Given this list of marker genes RNF168, SUSD5, SPOP, TENM4, AFF4, UBXN7, DNAJC7, TMEM47, CTDSPL2, B3GALNT1, TBX15, ZNF138, PYHIN1, RCN2, NDEL1, TSC22D3, FHL5 (NCBI Gene Id 9457), GPR180, ZNF559-ZNF177, PRKCB, PRDM10, BCLAF3, PIAS2, BMAL2, ZNF721, MSL2, DNAJC21 (NCBI Gene Id 134218), ZFP1, DSE, MSI2, SRSF10, RNF130 (ring finger protein 130), RCOR1, STXBP6, ANKRD28, MAN2C1, HNRNPR, TSPAN6, PFKFB2, ITSN2, SRPK1, SLC4A10, PTPRZ1, ZNF488, PPP2R5A, SH3BP5, TRAPPC10, AK4, CADM1, TSPAN5, ARG1, MIER3, SESN1, DNAJC8, SOCS6 (NCBI Gene Id 9306), RPGR, SAV1, TMPO, WNK1, ARID4A, ZNF302, ADAMTS6, FUNDC1, FUT9, KPNA2, TARBP1, QPCT, IRF2BP2, KRBOX4, RTN4, ACOX1, KIF2A, BAHD1, RAP2B, PGF, ZNF121, FAXC, KCNMB2, ELAPOR2, KIT, AMER2, KDM7A (lysine demethylase 7A), SCN7A, PTBP2, GLS, GAPVD1, FRA10AC1, ZNF257, CAVIN2, OBI1, RANBP1, PIAS1 (NCBI Gene Id 8695), FN1, MYO6, STAG1, MEX3C, EHF, ARMC2, ZNF117 (zinc finger protein 117), RLIM, ZNF75A, ZBTB20, CPNE3, PUM1, IL22RA2, USP42 (ubiquitin specific peptidase 42), FZD3, CALCRL, RICTOR, PCGF2 (NCBI Gene Id 7703), BSN, CHIC1 (NCBI Gene Id 53344), IL15, ZNF586, DUS1L, ARRDC3, GPATCH8, CCL13, SEMA3A, BICRAL, LRRC8C, USP9X (NCBI Gene Id 8239), RAB6B, MBNL2, ZNF844, NECTIN3, ZNF99, NUP58, IKZF3, ZNF266, SLC7A14, GRPEL2, RXRA, FGL2, CAMTA1, VSIG1, FAM53C, DEPTOR, TIGD3, QKI, ATG2B, BAZ2B, POU2F3, CACYBP, ZNF780B, GREM2, ZNF426, TMEM168, B3GNT2, CCL2, PCDHB2, MIA3, TMEM170B, TIAM2, GALNT3, SPICE1, CPSF6, PROCR (protein C receptor), OSTC, THOC2, NID1, TRIM44, CLIC2, ARID2, EYA4, NAA16, ARL17A, M6PR, SGIP1, DDB1, AAK1, ARK2C, ZNF449, FAXDC2, DKK2, CNIH1, SMAP1, ONECUT2, IFIT1B, APIP, ZNF608, ZNF195, ARHGAP12, MIER1, TNRC6A, SAMSN1 (SAM domain, SH3 domain and nuclear localization signals 1), CASK, TRHDE, C2orf49, SECISBP2L, MLLT10, PIM2, ZNF268, GUCY1A2, SRP54, NEXMIF, ZNF704, ANO3, ZNF773, PKP4, SHANK2, AGPS (alkylglycerone phosphate synthase), ZNF544, ADH5, SIX3, G3BP1, SNRK, ASF1A (anti-silencing function 1A histone chaperone), PTPRC, NXPH2, SLC33A1, CDCP1, SLC16A1, YTHDF1, PAWR, ZNF154, MET, CRK, ZFYVE26, TAF5L, FBXO42, INTS6, CDYL2, KBTBD11, GYPA, RHOU, RASEF, ZDHHC17, CREB1, ZNF569, HMGN4, SUB1, TRIM55, XRN2, PABPC4L, ZNF37A, CADM2, SRSF6, ZNF189, ZNF155, ENOX1, SLC30A9, NEK7, PALS1, CA13, ADD3, MAGT1, LCOR, TNPO1, ZNF552 (zinc finger protein 552), TLCD4, GRIK2, SPAG9, ZBTB14, MACO1, AZIN1, MAGEB18, ZDHHC21, FBXO48, NR3C1, SEC62, FUT10, CCDC34, FBXL2, TRIM37, TESMIN, IFTAP, POU2F1, KDM5B, ZNF800, B9D1, PRPF38B, MTRES1, CCDC57, GNAQ, EXOC6, CKAP2L, SPIN1, RALGPS2, ZNF503, ASB1, NSD2, MED26, ZNF678, ERMN (NCBI Gene Id 57471), CERT1, HEPACAM2, OGT, SNAP25, SPO11, ZNF718, KCNJ15, CDK6, RBM15, TMTC1, SCGB2A1, SMAD5, DNER, CYLD, here is a description of the gene set: Human Gene Set: MIR3692_3P Genes predicted to be targets of miRBase v22 microRNA hsa-miR-3692-3p in miRDB v6.0 with MirTarget v4 prediction scores > 80 (high confidence targets). studied in species Homo sapiens from publication Chen Y, Wang X (PMID 31504780)